The following is a description of a gene set: species: Homo sapiens Human Gene Set: MIR5579_5P from publication Chen Y, Wang X (PMID 31504780) Genes predicted to be targets of miRBase v22 microRNA hsa-miR-5579-5p in miRDB v6.0 with MirTarget v4 prediction scores > 80 (high confidence targets)., and this is the list of marker genes: HNRNPR, HELZ, ZNF567, ZNF257, HOXC13, PLEKHA8, DSG4, RAB11A, CNTN1, TRAM1, SEC24D, RIC8B, MAN2A1, ICA1L, PHACTR2, RASGEF1A, THBS2, AMMECR1, GAPDH, ZNF521, MAFB, LZTS3, CDH6, IKZF2, SHTN1, ZCCHC2, NCAPG2, NR3C2, ASH2L, RYBP, PPP2R5A, NHS, ACTR3, SCN1A, BBX, PDE4A, KBTBD3, LAMTOR3, SLIT3, FBXO11 (F-box protein 11), CRAMP1, TXLNG, AADAT, CRH, PATZ1, COPS8 (NCBI Gene Id 10920), ZMYM1, ZFY, SIAH1, CYFIP2, CREB1, SIN3A, GUCY1A2, UBE3A, NECAB1, LTBP2, RBL2, KCNT2, MAP2K4, HDAC8, PAPPA (NCBI Gene Id 5069), KCND2, CCDC59, LONRF1, STAP1, GPHN, TFCP2L1, GJA3, RGS7, GNA13, DEPDC5, TAS2R20, FEM1C, MALT1, ZNF780A, C17orf100, PALMD, ANKRD42